Given this list of marker genes NHEJ1, TCF3, YY1, CYREN, POLB, XRCC4 (X-ray repair cross complementing 4), LIG4, PRKDC, here is a description of the gene set: Human Gene Set: GOBP_IMMUNOGLOBULIN_V_D_J_RECOMBINATION The process in which immunoglobulin gene segments are recombined within a single locus utilizing the conserved heptamer and nonomer recombination signal sequences (RSS). For immunoglobulin heavy chains V, D, and J gene segments are joined, and for immunoglobulin light chains V and J gene segments are joined. species: Homo sapiens